Given this list of marker genes Abca2, Mios, Cntn1, Ckap5, Mobp, Mag, Tenm4 (teneurin transmembrane protein 4), Tlr2, Ercc2, here is a description of the gene set: species: Mus musculus Mouse Gene Set: GOBP_CENTRAL_NERVOUS_SYSTEM_MYELIN_FORMATION The process in which the wraps of cell membrane that constitute myelin are laid down around an axon by an oligodendrocyte in the central nervous system.